The following is a description of a gene set: species: Mus musculus Impairment of the complex regulatory network of cell death and survival is frequently the reason for therapy resistance of breast cancer cells and a major cause of tumor progression. We established two independent cell lines from a fast growing mouse breast tumor (WAP-SVT/t transgenic animal). Cells from one line (ME-A cells) are sensitive to apoptotic stimuli such as growth factor depletion or treatment with antitumor agents (e.g. doxorubicin). Cells from the second line (ME-C cells), which carry a missense mutation at the p53 codon 242, are very insensitive to apoptotic stimuli. Co-cultivation experiments revealed that the ME-C cells mediate cell death resistance to the ME-A cells. Microarray and Western blot analysis showed that osteopontin (OPN) is selectively overexpressed by the ME-C cells. This glycoprotein is the most abundant protein secreted by the ME-C cells and we obtained strong indications that OPN is the main antiapoptotic factor. However, the OPN containing ME-C cell medium does not alter the expression level of pro- or antiapoptotic genes or known inhibitors of apoptosis (IAPs). Its signaling involves mitogen-activated protein kinase (MAPK)/extracellular signal-regulated kinase (ERK) kinase (MEK)1/2 as the kinase inhibitor PD98059 restores apoptosis but not the Akt inhibitor. In the ME-A cells, mitochondrial cytochrome c release occurs with and without external apoptotic stimuli. OPN containing ME-C cell medium does not prevent the mitochondrial cytochrome c release and caspase-9 processing. In serum starved ME-A cells, the OPN containing ME-C cell medium prevents caspase-3 activation. However, in doxorubicin-treated cells, although apoptosis is blocked, it does not inhibit caspase-3. This indicates that the ME-A cells distinguish between the initial apoptotic stimuli and that the cells possess a further uncharacterized control element acting downstream from caspase-3. from publication Graessmann M, Berg B, Fuchs B, Klein A, Graessmann A (PMID 17160024) Genes up-regulated in ME-A cells (breast cancer, sensitive to apoptotic stimuli) exposed to doxorubicin in the presence of medium concentrate (MC) from ME-C cells (breast cancer, resistant to apoptotic stimuli). Human Gene Set: GRAESSMANN_RESPONSE_TO_MC_AND_DOXORUBICIN_UP, and this is the list of marker genes: GSTA2, RBL2, NAA80, USP20, CDC25A, ULK1 (unc-51 like autophagy activating kinase 1), FAM110A, MSRB1 (NCBI Gene Id 51734), SEPHS2, NPC2, RAP2B, NT5DC3, PLEK2, PMM1, CUL4A, SPON2, HMG20B, ITGA6, ZNF185, MMD, FKBP9, TMOD1, CRLF1 (NCBI Gene Id 9244), STX3, ZNF394 (zinc finger protein 394), GSS, FA2H, BTG2, TPRA1, CLP1, CDK18, GPLD1, IL15, SH3YL1, ENDOG, SHMT2, RASA4B, INPP5B, ZNF764, IRAK1BP1, HLA-DRB1, HSPA1B, DEPDC7, RHOD (ras homolog family member D), SNX2, SURF4, ENO2, STARD10, LIF, ELAPOR1, GATA3, RBM38, UBE2T, ATP13A2, AGTPBP1, ZNRF2, GSTZ1, RBM43, ANGPT4, ASS1, CTSB, TWF2, LZTR1, TANGO2, RAB40C (NCBI Gene Id 64715), SELENOS, SSX2IP, PPP1R37, PCTP, AK4 (NCBI Gene Id 387851), ATP6V1D, PDXP, ARVCF, OAS1, LDB3, TCF7, DNAJC18, ARL16, EDEM1, HSD11B2, SRF, SNX16, PNP, GRINA, STAT1, TKFC, STARD5, LGALS3BP, GTF2B, DGKA, ALS2, NUDCD2, DAB2, UFSP1, SLC37A2, CPOX, ALDH4A1, CPT2, TTLL1, SLC20A1 (solute carrier family 20 member 1), FAH, EPHX1, TOR2A, DOP1B, SH3BGRL2, NATD1, IMPACT, TRIM32, RHPN2, S100A3, ARAP2, ZFYVE21, ANKRD17, DGKQ, RAP2A, SAC3D1, SNF8, CIRBP, PM20D1, CABYR, SERINC3, HAGH, ARHGAP27, SBK1, GPD1 (NCBI Gene Id 2819), SRR, GPR146, PURG, HGSNAT, DFFB, SIDT2, MAPRE1, GKAP1, CKAP2, FAM83H, UBALD2, CRACR2B, CAPN10, OVOL1, TRMT5, TRAFD1, SUSD6, EXOC4, RIPOR1, IFI30, PPP5C (NCBI Gene Id 5536), AHNAK, PDRG1 (NCBI Gene Id 96818), TRIM11, HRAS, RIDA, C19orf47, DNM2, CALHM2, ZFAND2A, CORO1A, FGF18, LPGAT1, CITED4, ZNRF1, SDHAF1, XRCC1, LASP1, PHLDA3, VEGFA, CBX1, ACAD11, AKR1B1, RAB11FIP5, ATP6V0B, APOF, FDXR, BET1L, COL18A1, CHAC1, ARPP21, LPIN1, HS6ST1, IFT27, PLA2G6, VASN, CRIP2, H2AC25, EMP3, PTP4A1, SLC7A7, MAPK9, ENDOD1 (endonuclease domain containing 1), GAL3ST1, TACC3 (transforming acidic coiled-coil containing protein 3), GGA2, STK17B, EXOC8, RALGPS1, GUSB, LMO4, RFNG, RXRB, TMC6, ZNF281, PTHLH, NANOS1, EOLA1, NINJ1, CLEC4G, DGAT2, ZNF703, TEPSIN, CROT, EIF4E3, CLBA1, CCDC117, ALDH1L1, SGPP1, PROCR, SH3GLB2, PKP1, ABTB1, ICAM5, PKDCC, CENPE, ECE1, SLC27A1, BRIX1, LYNX1, FAS, APAF1, MDM2, ATP6V0D1, MTARC2, GSN, TMEM191C, ZMIZ2, DRAM1, PTGER1, ENTR1, GDF15, DCAF1, EFNA1, KLHL22, SH3BGRL3, REN, ERGIC3, PTPN1, PCYOX1, SKIC8, UBA7, SMOX, PPP2R5D, EXTL1, PHGDH, RAB43, RAD9A, KLHL42, C6orf132, FAM32A, TOR3A, PYGO2, IL6R, INPP5D, CYP2F1, RB1, NDRG4, SMIM7, FZD7, PVALB (NCBI Gene Id 5816), CDR2L, RECQL4, ADRB2, HHATL, PTPN11, PPIF, RDM1, FZD5, ICMT, CTR9, PDE4DIP, TGFB3, DCAF4, PHYKPL, BAIAP2, NHERF2, PERP, NFATC3, ERCC5, RASSF5, HSBP1, DNAJC9 (NCBI Gene Id 23234), MAPRE3, CAMK2B, IRGM (immunity related GTPase M), AAMDC, TBC1D8, ST14, LRRC57, GTSE1, KCTD12, ANGPTL2, ITPKA, EHD4, ROGDI, ACAA1 (NCBI Gene Id 30), ALAS1, CD68, SCN1B, ADAMTS7, RNF103, RIC8A, PATZ1, WRAP53, PSRC1, KCTD10, CARHSP1, CXCR4, MSANTD5, SPA17, UTRN, PLAAT3, DDR1, ACAD8, SP6, NID2, PKP3 (NCBI Gene Id 11187), IDUA, PAQR4, SLC35A5, TFCP2L1, ZNF708, FEZ1, NBEAL2, GLUD1, SHISA2, PRKCD, USP17L24, HES6, UNC119B, CAPG, HOXA5, MPP4, H3C13, SAP18, DMPK, EFNB3, LY6D, NAPA, JADE1, FRMD8, CCS, WIPI1, ZNF385A, MCEE, ANGEL1, SLC25A29, HEXB, PPM1A, KLF17, LBX2, HBD, ST3GAL2, FBXW4, PDK4, SFI1, C11orf68, TINAGL1, EI24, TREX1, TMEM19, GEM, PTGR1, GLCCI1, SLC33A1, BCL2L11, CBY1, FBXL20, DAPK1, MAN2B1, NXN, TMEM158, TNFRSF18, PIAS3, LGALS9, IRF6, CELF4, ANKRD10, CRAT, ZNF503, ZBTB8A, SCMH1, DPH7, RUSC1, E2F1, RABGAP1, MYO1H, SLC25A22, DOLK, TRIM7, ETFDH, PADI2, PDLIM1, HPN, ATOX1, SLC19A2, SCARB1, LRRC56, NUDT22, EEIG1, OPLAH, MTFR1L, EFNB1, MMP15, PPM1B, PLPBP, SLC31A1, CYSRT1, DAXX, SLC6A8, MARVELD1, COPS9 (NCBI Gene Id 150678), AGPAT5, WNT7B, F11R, JUP, ABHD5, NLRX1, USP2, TM7SF3, MTHFR, TUFT1, POM121, CSTB, RNF135 (NCBI Gene Id 84282), GALM, PDGFB, RNF128, LRR1, MAFB, H3C14, TMBIM1, TSPAN13, MORC4, CASQ2, IDH1, ST6GALNAC4, FAM50A, DCBLD1, FLCN, RNASEH2C, NOS3, SPEF1, PLA2R1, TUBA4A, BMP1, PITPNC1, LRRC51, MRPL28, TLR2, PTPRVP, CES2, NDUFA11, H1-2, ISLR, KRT5, RIPK4, CORO2A, PRKRA, CNBD2, NAT9, C1QTNF1, N4BP2L1, ITGB4, MAPKBP1, KLF6, PRKD2, EFNB2 (NCBI Gene Id 1948), TGOLN2, ITGA2B, TSPAN33, BCAR1, SP110 (SP110 nuclear body protein), LANCL1, RPE, PLEKHG6, UBE2I, SLC18A1, MAP1LC3A, TNNI1, NPTX1, AMPD2, PADI1, PITPNM1, TMEM38A, PSAPL1, UBE2O, FAM43A, MXD3, STOML2, APOBEC1, COTL1, SRXN1, TPP1, NR4A1, PPP1R15A, ALOX12, GPN3, IKBKE, NAA35, ALKBH4, TP53INP1, IVD, HIGD1A, GPAT4, SPC25, MASP1, PFN2, MYCBP, SORD, UGT1A5, SNCG, DEXI, MSH6, PPM1M, PLEC, HMOX1, SLC9A1 (NCBI Gene Id 6548), CCDC166, OGFRL1, ATP6V0E2, IL18, OSGIN1, ROM1, FOSB, LACTB, FAM216A, STIM1, ACOT6, LMAN2, NCOA1, CDKN1A, MAFG, AOX1, RNF181, SLC66A3, LHX2, DNAJB2, TGM2, ATG3, ZNF296, FETUB, HSD17B4, H2BC4, PDGFA, TMEM150A, DPP7, CENPT, TMEM41A, ADAM8, FUCA1, ABCB10 (ATP binding cassette subfamily B member 10), PGF, DBT, ZMAT3, TMEM40, PITPNM2 (NCBI Gene Id 57605), TMEM184B, FOXJ1, S100A13 (NCBI Gene Id 6284), FBXO33, MXD4, LDLRAP1, SERPINB5, ACOX2, ABHD4, PRCP, ALDH2, POLK, SESN2, DUSP9, PDLIM5, DDIT4L, CNTRL, SDC1, TRAF4, EOGT, RNPEP, GPHA2, DNAJB9, SPRYD4, GNS, COL11A2, SLC12A7, IFITM10, SLC39A4, THYN1, DNAJB1, SH2D3C, TP53INP2, DCXR, POLRMT, RIN2, APOH, CD27, OPN1SW, ARMC7, PLXNB2, PADI3, TBX2, EGR2, LENG1, AK1, TBC1D24, GPSM1, HYAL2